Given this list of marker genes AHR, C2CD2L, SMC5, CENPJ, KDM6A, ADCY7, TRIP12 (thyroid hormone receptor interactor 12), MTX3 (NCBI Gene Id 345778), BLM, ESPL1, DHX36, TK1, CLDND1, PCYT1A, PPOX, IVNS1ABP, SLC28A2, SLMAP, UBE2V2, MDM2, ALKBH6, FYB1, GPR107, RNF103, ANGPTL2, MYNN, CCZ1, WDR83, LRRC42, ATP6V1A, ELMOD2, CCDC25, RABGAP1L, DEGS1, OXR1, NEU3, GINS1, GNAL, ZFC3H1, TTC21B, UPP2, PDE4D, XRN1, KIDINS220, KBTBD7, FUCA2, LSM12, RB1, ADNP2, SHCBP1, RUFY3, IKZF2, UCKL1, MAF, BAZ1B, ACTR8, ICOS, TOP2A, CDKN2C, SNX9, ACTR3, UBL3, MIR340, SLC25A28, NOM1, COG4, PNPLA8, RBM45, CCR9, LRRC45, PKN2, CNNM4, WDR44, CYLD, SLC35G1, ANKRA2, CFAP36, PAXBP1, PTPRVP, NSMAF, RAB11FIP4, RWDD1, RORA, IRF8, ITGAV, MATK, ARHGAP10, JAK2, N4BP1, ZNF729, DDX42, TRIM33, HNRNPH2, ANKRD13D, NUDCD2, TNFSF10, NMRAL1 (NmrA like redox sensor 1), RHBDD2, DDX46, NOL8, CEP112 (centrosomal protein 112), KIF1B, ANTXR2, MTCP1, TIAL1, GBP5, CD274 (CD274 molecule), SLC43A1, NEDD4, NAA16, IRF1, SNRPE, SEC62, TRUB1, SNTB2, AGPAT4, IL6ST, KIF11 (kinesin family member 11), IFT74, DEK, ZCCHC2, N4BP2L2, ATP2B4, INTS6, PDS5A, CBR4, APLP2, AKAP9 (A-kinase anchoring protein 9), PICK1, LRRC18, XRN2 (5'-3' exoribonuclease 2), NKTR, ZKSCAN3, TRPS1, H2AC8, PSME4, CEP350, ATAD1, ZCCHC4, CTSE, IQCB1, PPP4R3A, PPP2R3C, IPMK (NCBI Gene Id 253430), NXF2, LPGAT1, ACTA1, HMMR, ALDH16A1, DGAT1, CYBB, CSNK1D, TMEM67, LSM10, CDK11B, LY96, SEPTIN7, SLAMF6, GPR52, PHF14, here is a description of the gene set: from publication Haxhinasto S, Mathis D, Benoist C (PMID 18283119) Human Gene Set: GSE7596_AKT_TRANSD_VS_CTRL_CD4_TCONV_WITH_TGFB_UP studied in species Homo sapiens Genes up-regulated in T conv in response to TGF-beta: expressing constantly active form of AKT1 versus control. The CD4+Foxp3+ regulatory T cells play an essential role in maintaining tolerance via their suppressive function on conventional T cells. The intracellular signaling pathways that regulate Foxp3 expression are largely unknown. In this study we describe a novel inhibitory role for AKT in regulating de novo induction of Foxp3 both in vivo and in vitro. A constitutively active allele of AKT significantly diminished TGF-â induced Foxp3 induction via a rapamycin-sensitive pathway, establishing a role for the AKT-mTOR axis in Treg cells. Moreover, the observed impairment in Foxp3 induction was paralleled by a selective downmodulation of the imparted Treg transcriptional signature highlighting the importance of the balance of intracellular signals in Treg differentiation. Our results provide a basis for further elucidation of molecular mechanisms that regulate Foxp3 induction and identify AKT as an important negative regulator of this process.